The following is a description of a gene set: The component of a plasma membrane consisting of gene products and protein complexes that are loosely bound to one of its surfaces, but not integrated into the hydrophobic region. Human Gene Set: GOCC_EXTRINSIC_COMPONENT_OF_PLASMA_MEMBRANE species: Homo sapiens, and this is the list of marker genes: FARP1, CDH6, PPP1R9B, DCHS1, GNG12, CNR2, MYD88, PPP3CA, CDH9, C1QC, GNB3, CDH4, GNAQ, AP2M1, CNKSR2, GNAL, FBXO2 (F-box protein 2), JUP, GNAT2, CDH13, CTNND1, GNG14 (NCBI Gene Id 648044), GNG5B, CDH12, NOD2, JAK2, CARMIL2, TGM3, GNGT2, JAK3, GNAT1, GNAT3, CRKL, GNG4 (NCBI Gene Id 2786), AKAP9, GNG5, DTNA, GNA14, CDH7, CDH8, ARAP1, GNG7, CDH26, FGF22, CDH10, CDH19, APC, GNAI3, VWC2, CTNNB1, CDH17, GNG2, GNA15, GNA13, STXBP1, CDH1, CDH18, TIRAP, DNAJC6, TOLLIP, CDH24, CDH22, CDH11, TRAF3IP2, RNF10 (NCBI Gene Id 9921), GNGT1, GNG13, GNA11, APC2 (APC regulator of WNT signaling pathway 2), GNB1, MCF2L, SNAP91, GNB4, GNAS, AP2B1, GNG10, PCSK9, CUBN, CTNNA1, CDH23, CDH15, CDH2, CDH20, PLEKHA4, PICALM, SCRIB, GNAI2, CTNNA2, GNAO1, GNB2 (NCBI Gene Id 96628), TYK2, CDH3, C1QA, GNG3, GNB5, JAK1, GNG8, GNAI1, GNAZ, SARM1, CDHR3, GNG11, IRAK4, TRAF6, CDH5, GNA12